The following is a description of a gene set: Mouse Gene Set: GOBP_NUCLEAR_PORE_LOCALIZATION Any process in which nuclear pores are transported to, or maintained in, a specific location. species: Mus musculus, and this is the list of marker genes: Lmnb2, Ndc1, Fxr1, Lmna, Lmnb1